The following is a description of a gene set: studied in species Homo sapiens STING (stimulator of IFN genes; also known as MITA/ERIS/MPYS/TMEM173) is an endoplasmic reticulum (ER) resident, which is required for effective type I IFN production in response to nucleic acids. Indeed, select pathogen-derived DNA or RNA were shown to activate STING in human and mouse cells (Ishikawa H and Barber GN 2008; Ishikawa H et al. 2009; Sun W et al. 2009; Prantner D et al. 2010). Importantly, in vitro studies have shown that STING is essential for Mycobacterium tuberculosis (Manzanillo PS et al. 2012), Plasmodium falciparum (Sharma S et al. 2011) and human immunodeficiency virus (HIV) induced type I IFN production. Mycobacterium tuberculosis, plasmodium falciparum and HIV are three deadliest pathogens, which kill millions of people each year worldwide.<p>STING has been also implicated in type I IFN response which was stimulated by fusion of viral and target-cell membrane in a manner independent of DNA, RNA and viral capsid.<p>Under steady state conditions, STING is positioned at the translocon complex within the ER membrane. However upon stimulation with intracellular DNA it translocates from ER to perinuclear vesicles via the Golgi by mechanisms that remain unclear (Ishikawa H and Barber GN 2008; Sun W et al. 2009; Ishikawa H et al. 2009; Saitoh T et al. 2009). Mouse Sting trafficking in dsDNA-stimulated mouse embryonic fibroblasts (MEF) cells was found to depend on autophagy-related gene 9a (Atg9a) (Saitoh T et al. 2009).<p>STING was reported to function as a signaling adaptor or coreceptor in response to cytosolic dsDNA (Unterholzner L et al. 2010; Zhang Z et al. 2011). STING was also shown to function as a direct DNA sensor to induce the innate immune response in human telomerase fibroblasts (hTERT-BJ1) and murine embryonic fibroblasts (MEFs) (Abe T et al. 2013). Additionally, STING is thought to function as a direct sensor of cyclic dinucleotides. STING was shown to interact directly with c-di-GMP in human embryonic kidney HEK293T cell lysates (Burdette DL et al. 2011). Once STING is stimulated, its C-terminus serves as a signaling scaffold to recruit IRF3 and TBK1, which leads to TBK1-dependent phosphorylation of IRF3 (Tanaka Y and Chen ZJ 2012).<p>Mouse, but not human STING, can also bind vascular disrupting agents 5,6-dimethylxanthenone-4-acetic acid (DMXAA) and the antiviral small molecule 10-carboxymethyl-9-acridanone (CMA) to induce type I IFN production, suggesting a species-specific drug effect on the STING-mediated host response (Conlon J et al. 2013; Cavlar T et al. 2013). Reactome Pathway: STING mediated induction of host immune responses part of: Cytosolic sensors of pathogen-associated DNA , and this is the list of marker genes: NLRC3, NLRP4, STAT6, XRCC6, PRKDC, TRIM21, IRF3, MRE11, DTX4, XRCC5, TBK1, STING1, IFI16, CGAS, DDX41, TREX1